Given this list of marker genes Ino80dos, Plekhb1, Mtf2, Ino80d, Mrpl30, Gm27343, Mitd1, Pgk1, here is a description of the gene set: from publication Yevshin I, Sharipov R, Kolmykov S, Kondrakhin Y, Kolpakov F (PMID 30445619) studied in species Mus musculus Mouse Gene Set: REX2_TARGET_GENES